Given this list of marker genes PDE1C, RAB11A, TP53TG3D, CNTN5, ENPP2, H2BC12, METTL21C, TMEM116, TP53TG3C, SOX11, ARID2 (NCBI Gene Id 57676), SLC40A1, PLAG1, CTNND1, ZFP41, G6PC2, NUFIP2, DPT, TGFBR1, TAFA1, DICER1, KIF3B, CNOT4, RSPRY1, RREB1, EPHA6, FAM98A, ZNF28, WNK3, HACD2, FAM117A, DCX, RAP2A, YBX1 (Y-box binding protein 1), KAT7, GAN, CLASP2, IBTK, MEF2A, TANC2, SHB, BCL2L11, MAP3K21, TTYH2, WWTR1 (WW domain containing transcription regulator 1), TM2D3, GATAD1, DCLK1, ANKRD50, RAB22A, ASTN1, TBC1D5, BRMS1L, TSHZ3, KCTD9, SORT1, RAB8B, RDH13, PPAT, VEZF1, ROR1, EIF5B, TP53TG3B, COCH, VGLL4, PDE7A, IKZF2, ZNF813, GAPVD1, GARIN3, MOCS3, CASP2, PTCHD1, PPP4R3A, SUCLG2, C2orf69, SLC35B2, DNAJC6, CNOT2, SH3PXD2A, RD3, ATAD2B, PCSK6, SETD3, EBF1 (EBF transcription factor 1), ARAP2, PPP3CA, FSTL5, WSB1, MTCP1, TRIM59 (NCBI Gene Id 353185), ZNF648, TP53TG3, NFIB, CTR9, LMLN, ABHD17C, USP33, MAP1B, ICE1, SNTG2, SRSF9, FAM8A1, TMEM62, ADAM7, ADAMTS15, NYAP2, RNF19A, MAML3, FAM168B, ZNF597, UHMK1, PPP2CA, GLIPR1L2, KLHL7, VMP1, COL12A1, CPEB3, FAM217B, FGF2, ZFR, ALDH1A1, NEUROG1, HJV, AKT3, RHOT1, POLDIP2, FOXP1, KIAA0232, KIAA0513, UBE2F, SMARCE1, UBE2G1, BCORL1, TBC1D19, RAB35, here is a description of the gene set: Genes predicted to be targets of miRBase v22 microRNA hsa-miR-17-3p in miRDB v6.0 with MirTarget v4 prediction scores > 80 (high confidence targets). studied in species Homo sapiens from publication Chen Y, Wang X (PMID 31504780) Human Gene Set: MIR17_3P